Given this list of marker genes Vps35, Oprm1, Wls, Tmem132a, Ptpn23, here is a description of the gene set: Any process that modulates the frequency, rate or extent of the controlled release of a Wnt protein from a cell. species: Mus musculus Mouse Gene Set: GOBP_REGULATION_OF_WNT_PROTEIN_SECRETION